Given this list of marker genes INPP5K, INPP5J, INPP5E, INPP5A, OCRL, SYNJ2, SYNJ1, INPP5B, INPPL1, INPP5D, here is a description of the gene set: Catalysis of the reactions: D-myo-inositol 1,4,5-trisphosphate + H2O = myo-inositol 1,4-bisphosphate + phosphate, and 1D-myo-inositol 1,3,4,5-tetrakisphosphate + H2O = 1D-myo-inositol 1,3,4-trisphosphate + phosphate. Human Gene Set: GOMF_INOSITOL_POLYPHOSPHATE_5_PHOSPHATASE_ACTIVITY species: Homo sapiens